The following is a description of a gene set: species: Mus musculus Any process that stops, prevents, or reduces the frequency, rate or extent of coagulation. Mouse Gene Set: GOBP_NEGATIVE_REGULATION_OF_COAGULATION, and this is the list of marker genes: Tmx1, F11, Thbs1, Ceacam1, Prkcd, Klkb1, Sh2b3, Apoe, Kng2, Fga, Vtn, Pdgfa, Prkg1, Psg23, Serping1, F2, Serpine1, Gp1ba, Fgg (NCBI Gene Id 99571), Anxa2, Anxa5, C1qtnf1, Kng1, Hrg, Adtrp, Tfpi, Tspan8, Plaur, Cpb2, Fgb, Plau, Pros1, Adamts18, Ubash3b, Procr, Tpsab1, Pdgfb, Alox12, Gp5, Serpinf2, Tmprss6, Apoh, F12, Hs3st5, Pdgfra, Plat (NCBI Gene Id 51950), Thbd, Cd9, Proc, Serpine2, Plg